Given this list of marker genes Pkmyt1, Pdik1l, Ccnb2, Ttk, Ndc80, Mapk15, Mos, Cdc20, Zwint, Knl1, Ovol1, Usp17le, Stk35, Cdc25b, Cdc25c, Cdc25a, Chfr (NCBI Gene Id 231600), here is a description of the gene set: studied in species Mus musculus Mouse Gene Set: GOBP_MEIOTIC_CELL_CYCLE_PHASE_TRANSITION The cell cycle process by which a cell commits to entering the next meiotic cell cycle phase.